Given this list of marker genes Ebf1, Bcl2l2, Pianp, 1700009N14Rik, Nipbl, Trp63, Srr, Dazap2, Fzd1, Dpysl3, Cdc5lrt7, Atp2b3, Esrra, Pou2f2, Odf1, Card14, Musk, Ccdc88c, Chmp2a, Shcbp1, Bcl10, Ncl, Dlg2, Cabin1, Drd4, Nphs1, Nod1, Hax1, Arhgap17, Vapa, Pou3f3, Nlrp1a (NLR family, pyrin domain containing 1A), Kctd13, Afap1l2, Nlrp2, Fzd2, Hnrnpk, Trim16, Abcc2, U2af2, Hspa1b (heat shock protein 1B), Ywhab, Lrrfip2, Adgrl2, Map4k3, Dnmt1, Mef2c, Ripk1, Ap2m1, Cacng3 (calcium channel, voltage-dependent, gamma subunit 3), Whrn, Prkar2a, Ddit3, Nup62, Trim9, Atxn2, Scnn1g, Gja1, Ica1, Lamp1, Ikzf4, Scamp1, Arf1, Nlrp1b, Hspa1a, Kif14, Igbp1, Cdk2, Wasf2, Slamf1, Shisa9 (shisa family member 9), Nefl, Tpm1, Pou2af1, Angel1, Caskin1, Jdp2, Enkur, Ndfip1, Inppl1, Crx, Ptpn6, Lnx2, Smad2, Bax, Src, Cd40, Pycard, Cacna1c, Oaz3 (NCBI Gene Id 53814), Prox1, Sgip1 (NCBI Gene Id 73094), Cnot1, Chmp2b, Jun, Myo7a, Ptpn22, Trim65, Nkd1, Insc, Zfp384, Plekha1, Wbp2nl, Traf4, Heyl, Dynll1, Bcl2a1b, Oprm1, M6pr, Arhgap1, Itgb1bp2, Acvr2a, Ppara, Irf3, Nlk, Wnt1, Atp2b1, Cited2, Ikbkg, Bok (BCL2-related ovarian killer), Hoxa3, Chmp1b, Plxnb3, Dvl2, Bcl2a1d, Prrt2 (NCBI Gene Id 69017), Ezr, Skp1, Wipf1, Gata1, Vcp, Ctbp1, Dock3, Ehmt2 (euchromatic histone lysine N-methyltransferase 2), Prkcd, Gapdh-ps15, Trak2, Tacc1, Hhex, Dnm1l (NCBI Gene Id 74006), Trp53bp2, Twist1, Acox1, Cabyr, Skap1, Hoxc4, Dnajc6, Ppargc1b, Kcnab1, Qki, Stx1b, Plxnd1, Basp1, Khdrbs1, Sp100, Sh2d2a, Bhlhe40, Rapgef2, Aatf, Zfyve9, Xpa, Gng5, Pawr, Homer2, Cltc, Ppil1, Kcna1, Itga3 (NCBI Gene Id 16400), Pxn, Mrtfa, Ski, Irgm2, Cdc5lrt1, Fmn1, Dab2ip, Adam10, Pias2, Pkd1, Sos1, Aip (NCBI Gene Id 11632), Rab8b, Srsf7, Shisa5, Lck, Syngr3, Rnf2, Egr2, Dgkh, Pax6, Ddb1, Hap1, Pag1, Gtf2f1, Grb2, Dlgap2, Hgs, Gng12, Mlf1, Actn2, Rara, Traf3ip3, Cdc5lrt6, Ajap1, Csnk2b, Slc34a1, Baiap2, Espn, Mypn, Ar, Ddx5, Ywhag, Lat2, Trim11, Rxra, Foxa1, Scn2a, Sesn2, Alx4, Fyn, Sdc2, Nos1ap, Ipcef1, Dlg3, Crim1, Cit, Mrps31 (NCBI Gene Id 80402), Wbp11, Pou2af3, Cd3e, Dlg4, Rabep1, Efs, Etv6, Sntg2, Crebbp, Olig2, Ddc, Lsm4, Nrl, Akap7 (A kinase anchor protein 7), Atp2b4, Vasp, Bmp2, Bcl2a1c, Fzd4, Tcf3, Scaf8, Tada3 (NCBI Gene Id 68474), Stx18, Lbr, Rcc2, Dmd, Ocln, Srrm2, Klhl17, Cldn7, Rb1, Srcin1, Arhgap6, Dnm2, Grm7, Lin7a, Shank1, Hspa5, Bmi1, Ifih1, Npcd, Myo5a, Inpp5j, Mavs, Cyba, Sh3gl1, Atn1, Fkbp8, Tjp1, Kcnj12, Crk, Uvrag, Actn1 (NCBI Gene Id 94278), Hnrnpa1, Rps6kb1, Cntnap4, Ddx6, Il1b, Wnt3a, Lpar2 (NCBI Gene Id 53978), Cxadr, Ppp1cc, Mrpl17, Gapdhrt2, Zmynd8, Hspa2, St13, Kcnn2, Gja5, Casp9, Xpo1, Homer3, Dicer1, Cpe, Prrx2, Dock4, Nkx3-1, Dennd1a, Siah1a, L1cam, Pick1 (protein interacting with C kinase 1), Arhgap27 (Rho GTPase activating protein 27), Scn5a, Cdc42, Rad9a, Top1, Dixdc1, Cttnbp2, Plaur, Plscr3, Ptpn12, Ppp1r2, Tacc3, Tjp2 (tight junction protein 2), Clec3b, Gopc, Runx2, Cdc5lrt4, Thra, Slc22a12 (NCBI Gene Id 20521), Snca, Trex1, Fut8, Lin7b, Cblc, Gnai3, Wnt3, Sntb1, Wt1, Strn3, Epb41l5, Osbp, Sqstm1, Srsf9, Strn, Ptpn11, Skil, Pmf1, Gata2, Acsl3, Xrcc4, Smtnl1, Grip1, Picalm, Casp1, Card9, Inpp5d, Tmem88, Nherf1, Srsf1, Dnaja1, Ostf1, Plekha2, Dlg1, Rack1, Phrf1, Trak1, Hdac2, Tgm2, Zfp653, Dbnl, Hes1, Bcl2l1, Adam17, Ilk, Sh2b2, Gabrr2, Sh3pxd2b, Nfe2l1, Numa1, Cnot9, Mitd1, Nod2, Chaf1a, Hif1a, Muc17, Ikzf5, Slc26a6, Arhgef16, Zxdc, Mvb12a, Dffa, Ap4m1, Sh3bgrl2, Ica1l, Myd88, Tfdp2, Cdc5lrt9, Drd3, Irs2, Capn7, Arr3, Cftr, Trp53, Nedd4, Scaf1, Atp2b2, Ehmt1, Ets2, Keap1, Zfp592, Apobec1, Kcnj9, Sh3bp1, Rhoq, Erc2 (NCBI Gene Id 52497), Slc9a3, Pik3r1, Hif1an, Ccna2, Cul3, Fzd8, Was, Wipf3, Abl1, Tnks1bp1, Cxxc4, Tacc2, Pirb, Hcls1, Nolc1, Wiz, Clcn3, F11r, Aqp2, Pcgf6, Enah, Calm3, Pttg1, Dlc1 (NCBI Gene Id 50768), Pou5f1, Dtna, Rims2, Psen1, Stmn3, Jak2, Llgl2, Ap2a2, Nfasc, Hnrnpm, Myb, Dag1, Vapb, Shank2, Insr, Plscr2, Syk, Scnn1a, Ywhae, Zxdb, Cdkn2a, Atf2, Srp68, Dlgap1, Stub1, Taf9, Ldb1 (NCBI Gene Id 16825), U2af1, Pou2af2 (POU domain, class 2, associating factor 2), Tln1, Atf4, Pias1 (protein inhibitor of activated STAT 1), Hcn2, Vps11, E2f4, Th, Isl1 (NCBI Gene Id 16392), Pax2, Tom1l1, Trim28, Arhgap5, Fzd7, Pparg, Nfe2, Inpp5a, Tra2b, Erc1, Cadm1, Mecp2, Slc22a4, Chd8, Srp72 (NCBI Gene Id 97219), Noxa1, Cdc5lrt5, Ghr, Adam15, Prkn, Hsp90aa1, Rab27a, Eps15, Slc22a5, Grid2, Terf1, Thap7, Atxn1, Robo1, Cldn16, Ywhaz, Axin1, Foxa3, Cebpa (CCAAT/enhancer binding protein alpha), Vrk2, Ywhah, Dlgap4, Ms4a2 (membrane-spanning 4-domains, subfamily A, member 2), Srsf5, Ncoa2 (NCBI Gene Id 52119), Exoc4, Synj1, Adam12, Fadd, Wnt5a, Arfip2, Pals1, Dap, Dnm1, Mpp7, Atrx, Son, Sh3bgr, Mtor, Lyn, Pak3, Casp8 (NCBI Gene Id 12370), Iqgap1, Stk11, Adam19, Stambp, Mapt, Ncf1, Itpr1, Med1 (NCBI Gene Id 19014), Rufy1, Kcnh2, Dlgap3, Ywhaq, Gab2, Adgrb1, Shc4, Cited1, Snap91, Prrg4, Ogt, Dlx5, Epha4, Cd2ap, Syp, Tcap, Chek1, Cacna1d, Elmo2 (NCBI Gene Id 73997), Abi2, Sstr2, Armc10, Bcar1, Tcf7l2, Cntnap1, Zfp106, Pdcd6ip, Rdx, Myo1d, Ctnnb1, Hdac1, Calm1, Khdrbs2, Chmp1a, Id3, Map1lc3b, Usp8, Tcf12, Ssx2ip, Itgb1, Pax3, L3mbtl1, Shisa6, Epb41l2, Litaf, Rab27b, Gckr, Acp1, Kif21a, Prkar1a, Rapgef3, Spn, Cdc5lrt10, Gria2, Tnk2 (NCBI Gene Id 53909), Calm2 (NCBI Gene Id 75700), Rela, Gpsm2, Mical1, Plscr1, Siglecg, Reps1, Pten, Kcnj4, Abtb3, Nfe2l2, Ppp3r1, Hivep1, Trpv4, Adrb1, Usp47, Rgs6, Cdc25c, Mpp2, Sh3bp2, Ppp2ca, Errfi1, Hspa8, Utf1, Nol3, Ripk2, Fgfr1, Hpcal4, Ldb2, Cacnb1, Ctnnd1, Cask, Ncoa6 (nuclear receptor coactivator 6), Lax1, Styx-ps, Rab6a, Mpp3, Lin7c, Cbl, Ddx20, Bcl2, Ubqln1, Gpr37, Pkd2, Hmgb2, Nf2, Grik5, Lef1, Nr0b2, Snta1, Adam9, Evl, Gabrr1, Gapdhrt, Mdm2, Unc13a, Foxh1, Rap2b, Ctr9, Mbd2, Cdc5l, Tuba1a, Faf1 (NCBI Gene Id 99976), Nckipsd, Nck1, Tubb5, Tgfbr3, Hnf4a, Cabp1 (NCBI Gene Id 29867), Cntnap2, Twist2, Syngap1, Gapdh, Wbp1, Cenpj (NCBI Gene Id 219103), Capg, Pdzk1, Gpx1, Tead2, Arl1, Nde1, Ncam1, Map2k2, Ubr5 (NCBI Gene Id 97951), Gata3, Cdc5lrt8, Card11, Arhgap31, Igsf5, Zbtb21, Pde2a (phosphodiesterase 2A, cGMP-stimulated), Cntln, Shroom2, Lnx1, Tdg, Cbx3, Nr0b1, Ehd2, Nfkbiz, Cep250, Ube2i, Prkaca, Kirrel3, Zfp521, Cacnb2, Slc22a21, Kif20b, Grik2, Ndfip2, Casp4, Arfip1, Ptk2, Arrb2, Styx, Abi1, Prkar2b (protein kinase, cAMP dependent regulatory, type II beta), Dffb, Atp1a1, Prkce, Lrp2, Meox1, Hnrnpc, Spon1, Sh3bp5 (NCBI Gene Id 24056), Sorbs2, Aida, App, Afdn, Sirpa, Lonp1, Tamalin, Shank3, Igtp, Rrm1 (NCBI Gene Id 20133, ribonucleotide reductase M1), Bak1, Rufy2, Sh3bgrl, Gnas, Irgm1, Gabrr3, Rbm39, Akap5, Hmga2, Rims1, Bik, Lancl1, Ccdc88a, Rhoa, Foxa2, Dapk3, Scnn1b, Phaf1, Lpar1, Nlgn1, Ushbp1, Prrx1, Ran, Hoxb1, Ctnnbip1, Gria1, Cct6a, Lzts3, Ncor1, Cep68, Crb3, Rfc1, Khdrbs3, Arhgap29, Gipc1, Myh9, Ikzf1, Kidins220, Cacybp, Wars1, Cript, Elmo3, Kras, Epn3, Sirt1, Pink1, Irs1, Grin2c (glutamate receptor, ionotropic, NMDA2C (epsilon 3)), Atxn1l, Psmc3ip, Bcl2a1a, Tradd, Slc34a2, Lamp2, Kpnb1, Trps1, Apba1, Tbc1d10a, Hip1r, Samd11, Polr2j, Mospd2, Mafk, Vim, Rbmx, Hsp90ab1, Fzd3 (NCBI Gene Id 320969), Ncoa3, Map3k5, Nsf, Dab1, Klf1, Ccdc6, Strn4, Blnk, Plg, Rassf9, Luc7l, Snap25 (NCBI Gene Id 57077), Dock1, Cntrob, Entrep3, Ist1, Cdh1, Afap1, Synj2, Fmr1, Pakap, Elmo1, Tnni3, Stxbp1 (syntaxin binding protein 1, NCBI Gene Id 98927), Casp2, Tfdp1, Sh3kbp1, Rph3al, Gusb, Senp2, Rnf41, Arhgef4, Pmepa1, Cradd, Zbtb16, Ppp1r9a, Dtx1, Prkdc, Mcl1, Pou3f2, Kit, here is a description of the gene set: Binding to a specific domain of a protein. studied in species Mus musculus Mouse Gene Set: GOMF_PROTEIN_DOMAIN_SPECIFIC_BINDING